The following is a description of a gene set: The release of intracellular molecules (e.g. hormones, matrix proteins) contained within a membrane-bounded vesicle by fusion of the vesicle with the plasma membrane of a cell, induced by a rise in cytosolic calcium-ion levels. Human Gene Set: GOBP_CALCIUM_ION_REGULATED_EXOCYTOSIS studied in species Homo sapiens, and this is the list of marker genes: UNC13A, CDK5, STX1B, RPH3AL (NCBI Gene Id 9501, rabphilin 3A like (without C2 domains)), SYT6, RIMS3, SYT17, GNAI2, ATP2A2, SDF4, SYT10, ZP3, KCNB1, SCAMP5, SYT11, CBARP, SYT1, EQTN (NCBI Gene Id 54586), SYT3 (synaptotagmin 3), RPH3A, SYT4, RIMS1, PPP3CB, BAIAP3, TSPAN18 (tetraspanin 18), SYT13, VAMP3, ADRA2A, SYT15, CACNA1B, UNC13C, DOC2B, NOTCH1, UNC13B, RIMS2 (NCBI Gene Id 9699), NLRP5, VAMP2 (NCBI Gene Id 6844), SYT7, REST, SYN2, RAPGEF4, STX1A (NCBI Gene Id 6804), STXBP3, SYT2, SYT5, ARL8B, ZP4, HYAL3, SNAP25, RAB3A, SCIN, VAMP7, CDK5R2, STXBP1, SYT9, SYT12, CLTRN, SYT8, RAB3GAP1, DOC2A, RAP1B, TRPV6, CADPS2, PPP3CA, MYH9, STXBP2, CADPS